The following is a description of a gene set: from publication Chen Y, Wang X (PMID 31504780) Genes predicted to be targets of miRBase v22 microRNA hsa-miR-506-5p in miRDB v6.0 with MirTarget v4 prediction scores > 80 (high confidence targets). Human Gene Set: MIR506_5P species: Homo sapiens, and this is the list of marker genes: ITPKB, LIPT2-AS1, SRARP, EVI5, PPP1CC, SLC16A6, SOCS4, GLI2, HMCES, NMD3, SQOR, CERT1, OGFR, TBPL1, MDGA2, CUL9, BTBD17, PLPPR4, RTN4RL1, TMC5, CNOT6L, CYBRD1, VAMP7, MTNAP1, MSS51, FAM72A, DEPTOR, TRAPPC8, TNFRSF11B, MTERF4, SIPA1L2, DENND2C (DENN domain containing 2C), EIF2S1, LSAMP, CSNK1G3, HDAC6, TBC1D15, NRN1, SPRR2D, COX11, TRERF1, SBF2, GFER, C11orf54, PSME3, UTP14C, SERPINF2, ZNF732, PRPF8, ORC2, CTSW, EIF5AL1, ARHGAP18, DHX9, EIF4B, VSTM2L, CFHR5, CEP41, GRIA4, SCD5 (NCBI Gene Id 79966), SPON1, PNLIPRP3, DTL, LIN7C, THSD7A, CFAP100, NCKAP5, LRRC34, QKI, ATP2B4, SGIP1, RNF169, FTSJ3, ADNP (NCBI Gene Id 256440), RFX3, G3BP1, LPL, PPARA, UTRN, TMEM237, GNG2, CHORDC1, RAB38, RALA (RAS like proto-oncogene A), ZNF718, EDIL3, ACADSB, NXT1, RAD54B, ZBTB33, ANHX, LARP4, FAM72D, ITPRID2, NSMAF, LAMC1, MTDH, RORA, DCUN1D5, CALCR, WRN, FRG2C, COMMD3, ZBTB2, HLA-DQA2, AGBL3, PAN3, ATP8B2, DBP, FAM72C, TPSG1, ANAPC1, UTP18, TGS1, POLDIP3, SYNC, TULP3, EDAR, ANXA10, FAM72B, TNRC6B, ATP6V1A, TACC1, EPS15, EIF5A, SREK1IP1 (NCBI Gene Id 285672), MDFIC, HTR1F, NHLH2, TBC1D5, SMC5, NKRF, HAUS4, STN1, RCC2, TSHZ2, PLPP6